Given this list of marker genes HMOX1, SPINK1, IL6, MIF, OTULIN, IL37, PSTPIP1, CASR, PRSS2, HLA-B, SLC22A4, UNC93B1, TNFRSF1A, HLA-DPA1, NLRP1, IL10, ARPC1B, IL6ST, ELF4, LACC1, CPA1, IL12B, ERAP1 (NCBI Gene Id 51752), C2orf69, PRKCD, NLRP12, LMNA, PTPN22, IL1RN, MVK, STING1, IL36RN, PRTN3, ADA2, ARPC5, CTRC, IL6R, ITGB2, RNF31, MEFV, KLRC4, TRAF3, PSMB8, ITK (NCBI Gene Id 3702), XIAP, FAS, NFKBIL1, NLRP3, SH2D1A, IFNGR1, MLX, CFTR, C4A, STAT4, PSMB9, TRPV6, DEF6, CD244, HLA-DRB1, TBK1, PTPN6, CCR1, TICAM1 (TIR domain containing adaptor molecule 1), IL12A-AS1, CIITA, UBA1, CCN6, CTLA4, LYN, COPA, NCF4, TLR3, SYK, C1QB, HLA-DPB1, POMP, P4HA2, IL23R, CARD10, IL12A, ZNFX1 (zinc finger NFX1-type containing 1), TLR4, PRSS1, NLRC4, PLCG1, UBAC2, AP1S3, here is a description of the gene set: Abnormal circulating C-reactive protein concentration Human Gene Set: HP_ABNORMAL_CIRCULATING_C_REACTIVE_PROTEIN_CONCENTRATION Any deviation from the normal concentration of C-reactive protein in the blood circulation. studied in species Homo sapiens